Given this list of marker genes CCND2, FABP4, CASP8, G0S2, HGFAC, CCND1, here is a description of the gene set: Genes up-regulated in 3T3-L1 cells (fibroblast) induced to differentiate to mature adipocytes and then treated with a TZD derivative AD-5075, a PPARG activator. PPAR gamma is an adipocyte-specific nuclear hormone receptor. Agonists of PPAR gamma, such as thiazolidinediones (TZDs), promote adipocyte differentiation and have insulin-sensitizing effects in animals and diabetic patients. Affymetrix oligonucleotide arrays representing genes were employed to profile the gene expression responses of mature 3T3-L1 adipocytes and differentiating preadipocytes to a TZD PPAR gamma agonist in vitro. The expression of genes was significantly up- or down-regulated by more than 1.5-fold during differentiation and/or by treatment with TZD, and these genes were organized into 32 clusters that demonstrated concerted changes in expression of genes controlling cell growth or lipid metabolism. Quantitative PCR was employed to further characterize gene expression and led to the identification of beta-catenin as a new PPAR gamma target gene. Both mRNA and protein levels for beta-catenin were down-regulated in 3T3-L1 adipocytes compared with fibroblasts and were further decreased by treatment of adipocytes with PPAR gamma agonists. Treatment of db/db mice with a PPAR gamma agonist also resulted in reduction of beta-catenin mRNA levels in adipose tissue. These results suggest that beta-catenin plays an important role in the regulation of adipogenesis. Thus, the transcriptional patterns revealed in this study further the understanding of adipogenesis process and the function of PPAR gamma activation. species: Mus musculus Human Gene Set: GERHOLD_RESPONSE_TO_TZD_UP from publication Gerhold DL, Liu F, Jiang G, Li Z, Xu J, Lu M, Sachs JR, Bagchi A, Fridman A, Holder DJ, Doebber TW, Berger J, Elbrecht A, Moller DE, Zhang BB (PMID 12021175)